The following is a description of a gene set: from publication Wang H, Qiang L, Farmer SR (PMID 17954559) Human Gene Set: WANG_CLASSIC_ADIPOGENIC_TARGETS_OF_PPARG Peroxisome proliferator-activated receptor gamma (PPARgamma) activity is regulated through association with ligands that include the thiazolidinedione class of antidiabetic drugs, as well as derivatives of polyunsaturated fatty acids. Induction of PPARgamma target gene expression involves ligand-dependent reconfiguration of the ligand-binding domain (LBD), followed by recruitment of specific transcriptional coactivators. In this study, we have identified an amino acid (F372) within helix 7 of the LBD that is required for the response of PPARgamma to endogenous ligands. Additionally, the data show that this amino acid is also required for expression of a novel subset of adipocyte genes (group 2), including fibroblast growth factor 21 (FGF21), and that the FGF21 gene is a direct target of PPARgamma. Expression of the group genes is selectively repressed by the NAD-dependent deacetylase SIRT1 in mature 3T3-L1 adipocytes, since knockdown of SIRT1 through the constitutive expression of a corresponding RNA interference enhances their expression without affecting the expression of classic adipogenic genes, such as adiponectin and FABP4/aP2. It appears that many of the group genes repressed by SIRT1 in mature adipocytes correspond to the same set of genes that are selectively activated by treatment of fat cells with the PPARgamma ligand, troglitazone. These data support a role for helix 7 of the LBD of PPARgamma in regulating adipocyte function and suggest that inhibition of SIRT1 in adipocytes induces the same insulin-sensitizing action as PPARgamma ligands. Classic adipogenic genes (group 1) that are induced by PPARG during adipogenesis in 3T3-L1 preadipocytes. species: Mus musculus, and this is the list of marker genes: ADHFE1 (alcohol dehydrogenase iron containing 1), GLUL, ACSL1, DGAT1, RETN, FABP4, CRAT, PPARGC1B, AQP7, LGALS12, CFD, ALDH1A1, EPHX2, CD36, MGST3, SLC25A10, PNPLA2, CEBPA, CIDEC, FABP5, S100A1, HSD11B1, ORM1, PEX11A, PLIN4, NR1H3 (nuclear receptor subfamily 1 group H member 3), MGST1